Given this list of marker genes NOTCH3 (notch receptor 3), FZD1, WNT5A, FZD7, FZD5, HES1, NOTCH1, NOTCH2, SKP1, TCF7L2, MAML2, PSEN2, DTX4, DLL1, CUL1, ARRB1, SAP30, CCND1, FBXW11, APH1A, HEYL, PRKCA, JAG1 (jagged canonical Notch ligand 1), ST3GAL6, KAT2A, PPARD, RBX1, PSENEN, LFNG, DTX1, WNT2, DTX2, here is a description of the gene set: Human Gene Set: HALLMARK_NOTCH_SIGNALING Genes up-regulated by activation of Notch signaling. species: Homo sapiens from publication Liberzon A, Birger C, Thorvaldsdóttir H, Ghandi M, Mesirov JP, Tamayo P (PMID 26771021)